Given this list of marker genes H3c2, H2ac23, H2bc15, H3c1 (NCBI Gene Id 360198), H2ab3, H2bc11, H2ac20, H2bc1 (H2B clustered histone 1), H4c1, H4c6, H2aj, Kmt2b (NCBI Gene Id 75410), H2bc6, Sin3b, H2ac18, Kat2b, H2ac13, H3c4, Prmt1, H4c16, H3c14, H2bc12, H2bc7, H3f3a, H3c6, H2ac4, H2bc22, Cbfb, H2bc23, H2ac24, H2bc9, Ash2l, H4c8, Kmt2d, H2bc21, H2bc26 (H2B clustered histone 26), H3c11, Hdac1, H2ac8, H4c14, H3f3b, H2bc8, H4c18, H2ac15, H3c13, H3c3, H2ac12, H2bc24, H2ax, Rbbp5, H2ac6, H2bc3, H3c7, Wdr5, Kmt2a, H2ac19, H4c9, H2ac11, Setd1b, H2bc4, H4c2, H2ab1, Gata1, Prmt6, Setd1a, H2bc13, H2bc14, H3c10, H4c17, H4c4, H4c11, H2az2, H2ac22, Zfpm1, Sin3a, H3c15, H3c8, Ep300, H2ac10, H4c12, H4c3 (NCBI Gene Id 319155), H2ac7, H2ab2, here is a description of the gene set: RUNX1 regulates genes involved in megakaryocyte differentiation and platelet function Mouse Gene Set: REACTOME_RUNX1_REGULATES_GENES_INVOLVED_IN_MEGAKARYOCYTE_DIFFERENTIATION_AND_PLATELET_FUNCTION species: Mus musculus